The following is a description of a gene set: Increased axial length of the globe Abnormal largeness of the eye with an axial length > 2.5 standard deviations from population mean. Human Gene Set: HP_INCREASED_AXIAL_LENGTH_OF_THE_GLOBE studied in species Homo sapiens, and this is the list of marker genes: CPSF1, FBN1, SCO2, WDR26, LRPAP1